The following is a description of a gene set: studied in species Mus musculus Mouse Gene Set: chr18A1, and this is the list of marker genes: Gm2424, Zeb1os1, Gm22470, Osbpl1a, 4921524L21Rik, Gm24924 (predicted gene, 24924), Epc1, G430049J08Rik, Cetn1, Gm5687, Gm5160, Lyzl1, Arhgap12, Mir1901, Gm21055, Gm20147, Gm41669, Ankrd29, Mir133a-1 (NCBI Gene Id 387151), Impact, Gm7274, Gm18763 (NCBI Gene Id 100417683), Gm26682, Vmn1r-ps152, Rmc1, Gm26244, Gm24292, Gm7575, Gm18948, Gjd4, Gm16072, Kctd1, Kif5b, Gm7599, Gm7411, Gm7502, Vmn1r-ps151, Gm10350, Gm10557, 4930545E07Rik, 4833419F23Rik, Zeb1 (zinc finger E-box binding homeobox 1), Esco1, Gm10556, Crem, Lama3, Bambi, Gm6248, Gm29201, Npc1, Gm7464, Gata6, Ttc39c, Cables1, 4933424G05Rik, Gm46641, 1700001G01Rik, Mkx, Gm41664, Ss18, Cul2, Abhd3, Gm9474, Rbbp8, Greb1l, Wac, Gm7523, Rab18, Gm4834, Fzd8, Mir1948, 4921533I20Rik, Gm19052, Gm5047, Rpl27-ps3, Gm18581, Mrpl27-ps, Gm15328, Gm7400, Gm2350, Mib1, Nutf2-ps2, Cdh2, Gm5819, Gm7497, Rock1, Tmem241, Mir1893, Gm2629, Gm9993, Usp14, Jcad, Gm38432, Chst9, Gm4835, Mir1b, 4930563E18Rik, Gm18713, Gm35232, Gm41668, Gm7670, Gm10036, Thoc1, Gm17430, Gm7665, Gm25289, Ccny, Map3k8, Gm5500, A830021F12Rik, Gm6225, Riok3, Gm6277, Snrpd1, Svil, Gm29200, Zfp521, Gm7466, Aqp4, Fabp5l2, 8430422H06Rik, Cabyr, Colec12 (collectin sub-family member 12), Hrh4, Odad2, Gm29992, Gm6457, Gm4833, Gm6291 (predicted gene 6291), Mpp7, Gm7532, Gm23350, Gm46633, Psma8, Gm7156, Gm5686, Gm6235, Mtpap, Gm35031, Gm34804, Gm7527, Gm5240, Gm18526, Mir1a-2 (NCBI Gene Id 723959), Gata6os, Gm18764, Gm7378, Gm41662, Gm5501, Gm25116, Taf4b, Vmn1r238 (NCBI Gene Id 100312476), Gm24228, 4930415O11Rik, Gm18083, Gm31086, Zfp438, Rpl7a-ps6, Mir133a-1hg